Given this list of marker genes IL6, RAG2, CEBPB, CDK4, B2M, IL21, RASGRF1, TNF, IFNA1, HOXA9, VPREB1, HMGB2, BCL3, HOXD1, FGF4, SOCS3, GFI1, CIITA, here is a description of the gene set: Human Gene Set: SHIN_B_CELL_LYMPHOMA_CLUSTER_5 from publication Shin DM, Shaffer DJ, Wang H, Roopenian DC, Morse HC 3rd (PMID 19010892) Cluster 5 of genes distinguishing among different B lymphocyte neoplasms. Aside from Myc-activating translocations characteristic of plasmacytomas (PCT), little is known about genetic factors and signaling pathways responsible for the development of spontaneous B-cell lineage lymphomas of mice. Here, we characterized the transcriptional profiles of PCT, centroblastic diffuse large B-cell lymphomas (CBL), and high-grade splenic marginal zone B-cell lymphoma (MZL++) using high-throughput quantitative reverse transcription-PCR. Expression profiles of CBL and MZL++ were strikingly similar and quite unlike that of PCT. Among the genes expressed at significantly higher levels by PCT were a number involved in NOTCH signaling, a finding supported by gene set enrichment analyses of microarray data. To investigate the importance of this pathway, NOTCH signaling was blocked in PCT cell lines by treatment with a gamma-secretase inhibitor (GSI) or transduction of a dominant-negative mutant of MAML1. These treatments resulted in reduced expression of NOTCH transcriptional targets in association with impaired proliferation and increased apoptosis. GSI treatment of transformed plasma cells in a primary PCT also induced apoptosis. These results integrate NOTCH activation with oncogenic signaling pathways downstream of translocated Myc in the pathogenesis of mouse PCT, two signaling pathways also implicated in development of human multiple myeloma and T-cell lymphoblastic lymphoma. species: Mus musculus